The following is a description of a gene set: electronically inferred by orthology from the curated human pathway species: Mus musculus This event has been computationally inferred from an event that has been demonstrated in another species.<p>The inference is based on the homology mapping from PANTHER. Briefly, reactions for which all involved PhysicalEntities (in input, output and catalyst) have a mapped orthologue/paralogue (for complexes at least 75% of components must have a mapping) are inferred to the other species. Reactome Pathway: Highly calcium permeable nicotinic acetylcholine receptors part of: Presynaptic nicotinic acetylcholine receptors, and this is the list of marker genes: Chrna4, Chrnb2